Given this list of marker genes BTK, ZP3, HLA-E, PARK7, FCGR1A, CCR7, FCER1G, C3, here is a description of the gene set: Any process that activates or increases the frequency, rate, or extent of an acute inflammatory response to an antigenic stimulus. Human Gene Set: GOBP_POSITIVE_REGULATION_OF_ACUTE_INFLAMMATORY_RESPONSE_TO_ANTIGENIC_STIMULUS studied in species Homo sapiens